The following is a description of a gene set: Human Gene Set: GSE22886_NAIVE_CD8_TCELL_VS_MONOCYTE_UP Genes up-regulated in comparison of naive CD8 T cells versus day 0 monocytes. from publication Abbas AR, Baldwin D, Ma Y, Ouyang W, Gurney A, Martin F, Fong S, van Lookeren Campagne M, Godowski P, Williams PM, Chan AC, Clark HF (PMID 15789058) Immune cell-specific expression is one indication of the importance of a gene's role in the immune response. In order to identify such patterns, we set out to broadly profile gene expression in a variety of immune cells. studied in species Homo sapiens, and this is the list of marker genes: GZMH, COL6A2, PRMT2, CD5, TFDP2, ITPR3, TMEM204, IL2RB, ADARB1, FHL1, GATA3, MSH2, SIRPG, NCALD, NOSIP, GRAP2, DPP4, ZMYND11, NPRL2, PRKCQ, NR3C2, ZNF573, SYNE2, GCFC2, AUTS2, BCL11B, TPD52, MAL, LPIN1, USP9Y, MYBL1, CD8A, ENO2, LIG1, ITM2A, GZMK (NCBI Gene Id 3003), ABHD14A, BACH2 (NCBI Gene Id 653980), LSR, TRMT11, BAG2, PLEKHB1, UBASH3A, METTL4, MACF1, MGAT4A, ADNP2, PPWD1, SPOCK2, JADE2, FLT3LG, MECP2, LBH, GPRASP1, TSPAN5, ITK (IL2 inducible T cell kinase), TRIB2, RAPGEF6, FCMR, CLK1, PTCH1, SH3YL1, ZNHIT6, CEP68, RWDD2A, EEIG1, PRR5, NCR3, SIDT1, DSC1, LINC00623, CLIC3, HMOX2, LINC00342, KLRB1, GNLY, CD96, DNAJB1, CD247, MLLT3, PJA1, IL18R1 (NCBI Gene Id 8809), CBLB, CD2, DNAJC9, IL18RAP, CD8B, GZMA, CD6, CD7 (CD7 molecule), NAA40, LIME1, IL21R, SMPD1, PVRIG, CAMK2N1, CD160, PTPN4, TSPYL4, LRRN3, SUPT3H, HOPX, CD3E, PDCD4-AS1, PRAF2, SMYD3, PRIM1, LRBA, RAB33A, CD3D, ZBTB25, TRAF5, S1PR1, DENND2D, LCK, PRMT1, CXCR3, LRIG1, PRKCA, RNF144A (NCBI Gene Id 9781), PLCG1, PTPRCAP, ITGA6, UNC119B, KLRG1, TGFBR3, LDLRAP1, LY9, EPHX2, KIF21B, ABCD2, ALDOC, SP140, RUNX3, GZMB, RRP1B, ZNF529, CD27, GPR18, RRAS2, P2RY10, YES1, ADPRM, KLRC3, HAUS3, KLRK1, DOCK9, NKG7, RORA, NRCAM, SLC38A1, LTB, KLF3-AS1, HSD17B8, ALDH5A1, ZSCAN18, NIPAL3, ZFTA, UNG, NAP1L3, CD28 (NCBI Gene Id 940), PRF1, TBC1D4, ADGRL1, MOAP1, SERPINI1, DDHD2, IL32, PASK, SLC39A14, NCK2, NUCB2, LEF1, MAGED1, AMMECR1 (NCBI Gene Id 9949), ABLIM1, ZAP70, INPP4B, ECHDC2, NELL2, CDC25B, GP5, CLEC2D, ZNF506, GPR171, SACS, BCAS4, ETS1 (NCBI Gene Id 2113), SKAP1, PDCD4, BNIP3, PDE3B, CD3G, CD69, GALNT12, LTBP3, USP11, SH2D1A, AKTIP